The following is a description of a gene set: Neighborhood of LTK leukocyte tyrosine kinase in the GCM expression compendium studied in species Homo sapiens Neighborhood of LTK Human Gene Set: GCM_LTK, and this is the list of marker genes: NR1H2, GRM4, ADD1, KRT32, ZNF8 (NCBI Gene Id 7554), NKX2-5, KRT6C, PLCB2, HSD17B3, RING1, FES, MADD, AMFR, SIRPB1, MICB (NCBI Gene Id 91956), FANCC, DRG2, PTPN5, ODF1, HTT, AQP2, GPER1, RABGGTA, MLN, TH, IDUA, PMS2P11, WAS, DGCR6 (DiGeorge syndrome critical region gene 6), GPR3, CCR9, KRT35, PSG7, MPP2, CSN3, BCL3, PLK1, ATM (NCBI Gene Id 8068), ADRB3, RENBP, SLC2A4, AANAT, UBE2D3, NEFL, HSF4, LTK